The following is a description of a gene set: A process that prevents non-homologous end joining at telomere, thereby ensuring that telomeres do not fuse. Mouse Gene Set: GOBP_PROTECTION_FROM_NON_HOMOLOGOUS_END_JOINING_AT_TELOMERE species: Mus musculus, and this is the list of marker genes: Pot1b, Dclre1b, Nbn, Xrcc1, Xrcc4, Terf2ip, Acd, Ercc4, Ercc1, Terf2